Given this list of marker genes CLN3, GLTP, PLTP, PLEKHA8, PSAP, RFT1, NPC2, CPTP, here is a description of the gene set: Human Gene Set: GOBP_GLYCOLIPID_TRANSPORT The directed movement of glycolipids, compounds containing (usually) 1-4 linked monosaccharide residues joined by a glycosyl linkage to a lipid, into, out of or within a cell, or between cells, by means of some agent such as a transporter or pore. studied in species Homo sapiens